The following is a description of a gene set: studied in species Homo sapiens During acute viral infections, naïve CD8+ T cells differentiate into effector CD8+ T cells and, after viral control, into memory CD8+ T cells. Memory CD8+ T cells are highly functional, proliferate rapidly upon reinfection and persist long-term without antigen. In contrast, during chronic infections, CD8+ T cells become “exhausted” and have poor effector function, express multiple inhibitory receptors, possess low proliferative capacity, and cannot persist without antigen. To compare the development of functional memory T cells with poorly functional exhausted T cells, we generated longitudinal transcriptional profiles for each. Genes down-regulated in CD8 T effector cells at day 6 of chronic infection: LCMV-Armstrong versus LCMV-Clone 13. Human Gene Set: GSE41867_LCMV_ARMSTRONG_VS_CLONE13_DAY6_EFFECTOR_CD8_TCELL_DN from publication Doering TA, Crawford A, Angelosanto JM, Paley MA, Ziegler CG, Wherry EJ (PMID 23159438), and this is the list of marker genes: TRAF1, SNRPF, CDKAL1, PCNA, NUP205, GEMIN8, NXT1, MVP, MFHAS1, NFKBIA, BCKDK, FEN1, CNOT9, PPAT, POMP, RANBP1, TTC1, CISH, TELO2, MRPL15, TOR3A, SLC7A1, COA5, C18orf21, TXNRD3, MLLT1, ZNF823, PRDX3, PUS7L, NRP2, PGAM5, GCLM, NEDD8, CARM1, TADA2A, NDUFAF5, ENPEP, LAGE3, PES1, TRMT10C, TXNRD1, ABT1, AP1G2, SWAP70, NUP85, PRPF3, MMAA, GTF3C6, SUPV3L1, SPI1, USP31, RHOT2, HSPD1, ZCCHC17, UBE3D, RELB, HSP90AB1, IFI35, ENOX2, ECHS1, MRPL32, XRCC5, TMEM216, LARS2, AASDHPPT, IDI1, PIGY (phosphatidylinositol glycan anchor biosynthesis class Y), CFLAR, PEX16, RCE1, GINS1, WDR74, RPP14, RAD23A, RSL24D1, COMMD9, CD40LG, IRF5, THUMPD1, PDCD5, DOT1L, CIRBP, POLE4, RHBDF1, MRPL40, FIBP, HMBS, OAS3, EIF3J, DYNLT2B, TARBP2, RAB1B, TRIM44, NUP188, CACNA1A, ATP6V1C1, UQCC2, MRPS11, EIF2AK4, WDR12, NSUN5, POLR2C, EFL1, YARS2, RPUSD1, WDR70, MTG2, LARP1, KAT2A, POLR2H, MTLN, PPIA, WDR5, DHDDS, AAR2, GABARAPL1, MTHFD1, ALG3, TPRKB, ETF1, AFP, COX18, YDJC, MRPS2, LSM7, DNAJC27, MRPS22, CPSF1, IMPDH2, RBMX2, ZNF619, CTR9, TTYH3, POLR2E, DNAJC11, OMA1, PPIE, LCMT1, MRPL52, PMPCA, ESAM, TMEM183A, LRP8, IFRD1, RCC1, FAF1, NOL12, MAGOH, EEF1AKMT2, USP5, ITPA, CYB5B, FKBP4, PSMD11, CNOT11, ASCL2, ELP2, MAT2A, PPAN, IFRD2, ZDHHC17, ZNF653, GTPBP4, FGF13, ITFG2, MYCBP2, CCT3, TCOF1, OBI1, ISY1, LLGL1, FAM210A, YKT6, ACTA1, LIAS, CCT2, TIGAR, SYTL3, UPF1, NDUFAF7, DHX37, EEFSEC (eukaryotic elongation factor, selenocysteine-tRNA specific), STIP1, C3orf38, CSE1L, MRPL58, TRAF3, UBTD2, MED31, ADAR, NDUFS4, QTRT1, UBE2F, STYX, COX10, GADD45B, CCL17, NSMCE4A, CPSF3, GINS2